Given this list of marker genes Fbl, Ctcf, Vdr, Top1, Ncl, Gar1, here is a description of the gene set: Mouse Gene Set: GOCC_DENSE_FIBRILLAR_COMPONENT A structure found in the nucleolus, which contains newly synthesized preribosomal RNA (pre-rRNA) and a collection of proteins. studied in species Mus musculus